The following is a description of a gene set: Downstream signaling of activated FGFR3 studied in species Homo sapiens Human Gene Set: REACTOME_DOWNSTREAM_SIGNALING_OF_ACTIVATED_FGFR3, and this is the list of marker genes: PIK3CA, FGF18, FGF1 (fibroblast growth factor 1), HRAS, SHC1, FGF20, PTPN11, PIK3R1, PLCG1, KRAS, FGF16, FGFR3, FGF17, SOS1, FGF23, GRB2, FGF9, FGF8, FGF5, GAB1, FRS3, NRAS, FRS2, FGF2, FGF4